The following is a description of a gene set: studied in species Homo sapiens Human Gene Set: MIR371A_5P from publication Chen Y, Wang X (PMID 31504780) Genes predicted to be targets of miRBase v22 microRNA hsa-miR-371a-5p in miRDB v6.0 with MirTarget v4 prediction scores > 80 (high confidence targets)., and this is the list of marker genes: BCCIP, EML4, PPAT (NCBI Gene Id 5471), ZNF264, SPAG9, WNK3 (WNK lysine deficient protein kinase 3), RHPN2, EVI2B, BCL10, COA3, FMO3, RPL15, MAP3K1, CNOT6, MAP3K5, ZNF706, GXYLT1, MYCN (MYCN proto-oncogene, bHLH transcription factor), RNF170, HOOK3, GPATCH2L, AAK1, SCAI, ZNF644, RIMKLB, PARG, SRSF2, SH3BGRL2, FAR2, ETV1, TRAF3IP2, SYCP2L, TIMM50, USP33, PLCB1, HBS1L, STK4, CST9L, RPGRIP1L, NEK3, CTNNA3, MKLN1, TLK1, AP1G1, PTGER3, IFIT2, RIMS1, HECW2, KIAA0232, PCDH8, MACROD2, SANBR, VPS35, CBX5, TMOD2, TNRC6B, CPPED1, ANKUB1, NGRN, RASGEF1A, UTY, BECN1, TEAD1, CCNY, TAF11, OSER1, HMGB2, SOX2, TRRAP, CDK13, SYNJ2BP, SEC24A, SCN3B, SFR1, TTC39C, NIM1K, CSNK1A1 (NCBI Gene Id 55416), ZC3H6, IGF2R, NR4A2, ENOPH1, CHSY3, EPS15, KDM6A (lysine demethylase 6A), C2orf49, EPM2AIP1, LYRM4, MPL, TMEM50B, TBX18, RPS6KA2, ZDHHC3, NME5, LMLN, RPF2, MSL3, PPP4R3A (NCBI Gene Id 84644, protein phosphatase 4 regulatory subunit 3A), PGAP1, KRIT1, QSER1, HSPA13, CSK, ITGB8, UBFD1, DIRAS3, SPANXN5, CCDC126, CCSER2, CDC73, GCFC2, NUP50, MAPK8, EXOC5, BEND2, NIBAN1, RASGRF2, RABIF, PSMD12, NLGN4X, NKAIN2, COMMD8, ZNHIT6, CERK, C21orf91, SUZ12, USP32, PHTF2, SRSF3, BARD1, ABHD18, PPIG, CYP20A1, SS18, COL14A1, SMAP1, PHF12, KDM3B, ISL1, TSPAN2, SVBP, FNBP1L, FGD4, LYRM7, TMEM33, TRIM59, SIAH2, CITED2, CCDC50 (coiled-coil domain containing 50), ANKS1B, ANO6, SLC35E2A, ZMYM5, SLC16A7, HDX, FBXL20 (F-box and leucine rich repeat protein 20), TMEM106B, FGFR1OP2, OTP (NCBI Gene Id 23440), PCMTD1, NEXMIF, TMEM170B, CLPTM1L, BTG3, MAPRE1, SAR1B, HELZ, CELF1, BAG5, TET2, SUSD5, SCN9A, PSMG3, ZKSCAN1 (zinc finger with KRAB and SCAN domains 1), BCLAF3, KANSL2, ILDR2, RNF141